The following is a description of a gene set: studied in species Homo sapiens Human Gene Set: GLI1_TARGET_GENES Genes containing one or more binding sites for (GLI1) in their promoter regions (TSS -1000,+100 bp) as identified by GTRD version 20.06 ChIP-seq harmonization. from publication Yevshin I, Sharipov R, Kolmykov S, Kondrakhin Y, Kolpakov F (PMID 30445619), and this is the list of marker genes: ASAP3, SLC35E3, TREM1, MLF2, C2CD2, GABPAP, KRIT1, MED14, DLEC1, PA2G4, ZNF778, C3orf49P1, CDC16, HNF1A-AS1, GNRH1, F13A1, TRIM39-RPP21, RSU1 (NCBI Gene Id 6251), GPCPD1, SPG11, RHEB, CASP8, CPT1A, HMGN2P46, THUMPD3-AS1, KRTAP16-1, PARP2, ZBED5, TTC7A, LINC02035, CCHCR1, COL4A1, CRIM1, AMIGO2, PVRIG, FBXL12, KCNB1, CNOT8, LINC02198, PRG3, DHTKD1, TRIM33, PTPRO, DMXL2, GAPDHP25, LRRC30, YIPF5, NAP1L4, RBM19, SQLE, SLC23A4P, STAT6, ELP5, GCLM, ARHGEF10, AHCYP8, NANOGNBP3, EPN2, LINC02005, BANK1, GLRX, TRAF3IP2-AS1, SOX10, SNORA11C, XPO1, EHBP1L1, TAF13, RPL23AP76 (NCBI Gene Id 441781), XPNPEP1, ESRRA, PKP3, SRSF11, NPY5R (NCBI Gene Id 4889), SSUH2, SEPTIN7P11, TSC22D1-AS1, ANXA11 (NCBI Gene Id 311), DTNBP1, SNORA81, NSFL1C, GARNL3, FEZ2, ERCC5, IGLVV-66, CAPS, CEP164, PLB1, NRAS, TNS2, RMDN3, REG4 (NCBI Gene Id 83998), TNFRSF25, JAML, OR4R1P, CACNA1D, LRP8, DAP3P2, CROT, SNORA33, AMPD3, KHNYN, RPS26P52, RETREG1 (NCBI Gene Id 96119), KRT82, CARS2, RNF217, THADA, CNTN2, LINC01359, FAXDC2, HIBCH, ARRB1, B3GNT7, HDDC2, RNU6-769P, PDAP1, NREP, TECR, SMARCA2, OR4A47, GJC1, EFR3B, RPL36P20, ITIH1, ENSG00000266088, ITGB8, YWHAZP4, SATB1, SART1, ARMCX3-AS1, GPR82, EIF4A1, LINC01588, TMEM259, SBNO2, LINC02028, TOP1MT, DGAT1, CALCOCO2, CANX, FAM193A, S100A13, TRIM13, GRIN2B, HNRNPA1, UPP1, MLLT3, MECOM, TNK2, CADM4 (cell adhesion molecule 4), ATF7IP, STIMATE, RNA5SP301, EPHB6, CTBP2, XXYLT1, LNCHR1, LINC00664, AFP, PLAT, UNKL, SNORD49A, USP25, RPS2P6, XRN1 (NCBI Gene Id 54464), POGLUT1, KLF5, ZBBX, C4orf46P2, SPX, ACSS2, LMNB1, PKD1L2, METTL21AP1, AMN1, GABRP, LPAR6, MIA3, LDHAL6B, AHCY, MAP3K10, RPS29P10, KRT18, EHF, OR13K1P, TCIRG1, TRBV20OR9-2 (NCBI Gene Id 6962), RNU6-543P, MOK, MCF2L-AS1, PSMB3P2, BANP, FNBP1, BCL2L14, RNU6-1305P, SNORD45C, MPP3, AGBL5-AS1, SNHG17, S100A16, SCO1 (synthesis of cytochrome C oxidase 1), NDUFS3, TANC2 (NCBI Gene Id 80259), DPH2, CEP85L, RPL7P30, NLRP2, CBARP, FGFR1, GCLC, ENSG00000265445, ATOSA, RPL21P132, IPO7 (importin 7), NGFR-AS1, CSF2RBP1 (CSF2RB pseudogene 1), COL14A1, SDS, MRPL21, SNORD100, UBR4, RB1, UBAP2L, MIR5591, MRM2, KDM1A, TRAV34, RBP1, NAPA, CELF1, ENSG00000226409 (NCBI Gene Id 102723341), ATP6V0C, NARF-IT1, LINC02837, C19orf67, ERCC1, TMX4 (NCBI Gene Id 56255), UMPS, SDCCAG8, CD81, SNRPA1, THNSL2 (NCBI Gene Id 55258), COG5 (component of oligomeric golgi complex 5), HRG-AS1, PLSCR2, PTPRU, ABCC8, TXK, DLEU7, FOLH1, LINC00106, TUBB8P6, SUMO2P8, MGAT4EP, LINC02646, DVL2, ERC2, POLR1A, USP35, LINC02720, ASNS, ZNF516, CES2, BUD31, CCDC144BP, LINC02394, EIF2AK1, CYP3A43, MELTF-AS1, MTCP1 (NCBI Gene Id 4515), MTURN, IQSEC3, RNU6-259P, MIR3663HG (MIR3663 host gene), TOX4, RTF1, BMERB1, SELENOP, LINC02620, BIRC2, ATP10B, SLC25A11, RPL7AP15, DIO2, PACS1, ALOX12P2, TREML4, RDH13, RNU6-1, DYNC1LI2, LINC00578, CENPK, LMLN-AS1, SLC22A17 (solute carrier family 22 member 17), SNORA63B, CHERP, METTL5P3, MAST2 (microtubule associated serine/threonine kinase 2), RNU6-516P, SLC16A2, LINC01393, RPL23AP61, AKT2, SASH1, MTND4LP10, FAM228A, RPL30P7, PIK3R1, CDH1, ENSG00000249847, TRBV30, LINC02275, ZNF414, AGR2, EIF4A2, LCN9, NR1H3, PUS7, RNU4-2, RUNX3, CLN8, UBE2C, EPS15L1, AGBL5, UROD, LINC00710, SLC8A1-AS1, MMP24OS (MMP24 opposite strand), MICALL2, SERPINB9P1, PMP22, RPL28, MCTP2, SIRPD, TMPRSS13, GAU1, RPS5, TBC1D28, SPOCK1, GALK1, KCTD17, TSHZ2, EPB41L1, EDDM3A (NCBI Gene Id 10876), TRIO, GRIPAP1, PSMF1, RNU6-1301P, MIR8066, LDLR, COPS5, CCL19, SPATA7, GGA3, AMPH, NOP58, CFAP221, SEMA3C, LINC01772, CDC123, OR7A10, CCDC141, RBFOX1, ABCG1, SLC4A5, RYR3, SEMA5B, DUT, PEMT, WT1-AS, ATAD2, GRAMD1C, RNA5SP356, RPEP4, KRTAP6-1, IFT46, CDIPT, MIR8059, WHAMM, RNU6-314P (NCBI Gene Id 106481278), RPL19P2, RNVU1-22, RNU6-243P, STARD13-AS, ATM, RN7SKP14, LINC01480, TSSC4, PPARA, NUDT8, MAGI2, IPO8P1, C18orf15, ZFAND6P1, SYP, EML2, PBX1, CLDN34, TCTN3, GATM, APOOP1, GMFB, SND1, GGA2, RPL35AP36, SNORA48, SNX25, CACNA1A, ARB2A, AEN, SNORA63, TRBV14, BLM, RNU1-23P, POLE4, LINC02108, APOA4, MSH2, RMND1, IGHMBP2, TSPAN18, CPEB1, ETV6, LINC01392, TIMM8BP1, PEPD, SMARCD3, RFXANK, MARCHF11-AS1, DNM1L, C1orf131, TNS1, POU2F3, KIF6, BRD7P4, SPRY1, RWDD2A, NDUFV3, TMCC3 (transmembrane and coiled-coil domain family 3), MIR3945, DDX11, RN7SL465P, WDFY3, OR10K1, MAP3K12, ZNF335, SAMSN1, RPA3, FLNA, PODNL1, PPP1R12C, FXYD1, P3H3, ETV5-AS1, HMGN2P36, FLT1, HSD17B4, ENSG00000253348, ZDHHC7, ACKR2, EDEM3, PACRG-AS3, AMFR, ARTN, MRRFP1, CMC4, PLEKHA7, CHRM3-AS2, SPTAN1, TRIM39, AKAP8L (A-kinase anchoring protein 8 like), SH3D19, ATP2B1, GPBAR1, RNU6-15P (NCBI Gene Id 100302741), ARHGEF1, DCAKD, CD200R1L, RPS17P11, C19orf47, IFT20, RPL7L1P8, HECTD3, BRWD1, ZNF329, KRT8P21, PRC1, PDSS1P2, KANK2, UBE2F, RPH3AL, GNA11, S100A7A, TUBG1P, RNASET2, CCDST, SGSM1, RNU7-74P, AVIL, LINC01179, WDR4, WEE2-AS1, TBCK, TCF4, EML6 (EMAP like 6), ACTN4, LOH12CR2, SNORD45A, NDRG1, LINC02889, LINC01270, CPP, HDAC6, TANK, ENSG00000260466, ADCY7, DEGS1, CCDC192, KCNAB2, ALDH1A2, ZNF90P3, NCAM1, TCAF1, TBL1XR1, ULK4, SETD6, CDC42, ZNF574, MTND3P7, HSPA12A, IFNE, PILRA, MYOZ3, EBNA1BP2, CPA1 (NCBI Gene Id 1357), DCN, ENSG00000273507, MT1X, PLD2, PPIAP68, BICDL2, FAM106A, PRR5L, SRI, GBF1, LINC02279, ACLY, NADSYN1, ATP11B, UBBP4, STAP2, QNG1, BPTF, ZNF507, QARS1, ZNF385C, KBTBD4, ACP2, CNTNAP5, P3R3URF-PIK3R3, TRIM22, OR10Y1P, ENSG00000226097, MALAT1, SH3GL2, LINC02427, CFB, TMPRSS4, SLC13A3, NIPA2, SQSTM1, ATF7, CC2D1B, NMT1, TPRX1, NRDC, UBL5, YDJC, DDX56, TM7SF3, GSG1L2, TBX4, IL36G, RABGGTB, BDP1, AKAP9, SUMO2P21, ADAM22, RNA5SP326, LINC02583, CNPY1, ATP11B-DT, MIR4437, CPLANE1, SLC7A3, ADGRG4, GRM5, PIM2, SCARNA2, MTIF3, ENSG00000239153, ACE, DDR1, C1S, BCL2L15, RPL17P43, AKTIP, DCAF17, CRX, TFRC, CDC42BPA, P3R3URF, GPX3, ZFAND6, RNA5SP329, RNU6-494P, KCTD1, PSMD11 (proteasome 26S subunit, non-ATPase 11), LETMD1, SKIC3, CA5B, RNU6-798P, SCGB2B3P, TSPAN33, LINC01893, ZFPM2, HSH2D, RBM39